Given this list of marker genes CDKL5, SIK1, PSAP, KCNA1, SATB1, SCN2A, GABRG2, SCN1A, PIGQ, DMXL2, SCN8A, SLC32A1, CASK, GNAO1, GRIN2A, ARX, DPM2 (dolichyl-phosphate mannosyltransferase subunit 2, regulatory), GABRA1, KCNQ2, TRIM8, PNKP, GRM7, PIGP, NEUROD2, GRIN1, SCN1B, PRRT2, KCNQ3, SCN9A, ACSF3, KCNT1, SLC25A22, WWOX, PCDH19, here is a description of the gene set: Human Gene Set: HP_GENERALIZED_CLONIC_SEIZURE Generalized clonic seizure studied in species Homo sapiens Generalized clonic seizure is a type of generalized motor seizure characterized by sustained bilateral jerking, either symmetric or asymmetric, that is regularly repetitive and involves the same muscle groups.